Given this list of marker genes ABHD10, ABHD17C, ABHD17B, PPT1, LYPLA1, LYPLA2, ABHD17A, here is a description of the gene set: Human Gene Set: GOBP_PROTEIN_DEPALMITOYLATION The removal of palymitoyl groups from a lipoprotein. studied in species Homo sapiens